The following is a description of a gene set: The process in which an inorganic anion is transported across a membrane. studied in species Homo sapiens Human Gene Set: GOBP_INORGANIC_ANION_TRANSMEMBRANE_TRANSPORT, and this is the list of marker genes: XPR1, SLC20A2, SLC37A2, SLC4A11 (solute carrier family 4 member 11), SLC12A8, SLC6A2, ANO4, SLC26A4, GABRA1, SLC37A4, ANKH, SLC26A11, KCNK1, SLC17A1, UCP2, SLC12A5, TMC4, GLRB, CLCA4, GABRB1, GABRA2, MFSD8, SLC4A1, CLIC5, CLIC3, FXYD1, SLC37A3, CLIC2, SLC37A1, LRRC8A, GABRQ, SLC26A2, SLC4A9, CLCN1, GABRA5, GABRB3, BEST1, GABRE, SLC5A6, CLDN17, AQP6, GABRG1, CLIC4, GABRB2, SLC17A7, CFTR, KCNK2, SLC1A4, GLRA2, GABRA3 (gamma-aminobutyric acid type A receptor subunit alpha3), ANO1, SLC1A1, SLC26A7, GABRA6, SLC17A8, PACC1, SLC17A6 (solute carrier family 17 member 6), SLC25A14, CLCN6, SLC25A3, SLC26A10P, OCA2, ANO2, ANO10, SLC26A5, GABRR3, SLC25A27, VDR, SLC26A6, CASR, CLCNKB, CLCA1 (chloride channel accessory 1), GABRP, GABRR2, SLC26A3, SLC5A5, ANO6, RACGAP1, SLC20A1, ANO5, CLCA2, SLC5A8, SLC34A1, GABRA4 (gamma-aminobutyric acid type A receptor subunit alpha4), CLDN3, BEST3, CLCN4, GLRA3, ANO8, SLC12A3, CLIC1, BEST2 (bestrophin 2), SLC4A8, SLC1A7, ANO7, GABRR1, CLCC1, SLC13A4, CLCN3, ANO3, SLC26A9, SLC12A1, GABRG2, SLC26A1, SLC4A3, SLC26A8, GLRA1 (NCBI Gene Id 2741), SLC12A4 (NCBI Gene Id 6560), NMUR2, TTYH3, CLCN5, GABRD, CLCN2, GABRG3, APOL1, BSND, CLCN7, TTYH2, SLC12A2 (solute carrier family 12 member 2), FXYD3, SLC6A1, SLC12A7, SLC12A6 (solute carrier family 12 member 6), SLC12A9, CLDN4, SLC25A10, SLC4A2, CLIC6, SLC1A3, CLCNKA, SLC5A1, SLC13A1, ANO9, BEST4, TTYH1